Given this list of marker genes SLC22A6, SLC22A11, SLC22A7, SLC22A12, SLC22A8, here is a description of the gene set: Reactome Pathway: Organic anion transport by SLC22 transporters part of: SLC-mediated transport of organic anions species: Homo sapiens Organic anion transporters (OATs) mediate the renal absorption and excretion of a broad range of endogenous substrates and anionic drugs such as diuretics and NSAIDs. Five members belong to these polyspecific transporters (OAT1-4 and URAT1) and are predominantly expressed in the kidney (Koepsell H and Endou H, 2004; Rizwan AN and Burckhardt G, 2007; Ahn SY and Bhatnagar V, 2008).